Given this list of marker genes Sirt3, Klf15, Hdac2, Hint2, Sirt1, here is a description of the gene set: studied in species Mus musculus Any process that stops, prevents or reduces the frequency, rate or extent of peptidyl-lysine acetylation. Mouse Gene Set: GOBP_NEGATIVE_REGULATION_OF_PEPTIDYL_LYSINE_ACETYLATION